The following is a description of a gene set: species: Mus musculus The covalent attachment of a geranylgeranyl group to a protein. Mouse Gene Set: GOBP_PROTEIN_GERANYLGERANYLATION, and this is the list of marker genes: Pggt1b, Musk, Ptp4a2 (NCBI Gene Id 19244), Agrn, Rabggta, Chml, Fnta, Rabggtb, Chm